The following is a description of a gene set: Mouse Gene Set: GOBP_NEGATIVE_REGULATION_OF_HEMOPOIESIS studied in species Mus musculus Any process that stops, prevents or reduces the frequency, rate or extent of hemopoiesis., and this is the list of marker genes: Inpp4b, Cartpt, Il17d, Hmgb3, Bcl6, Pilrb1, Id2, Clec2d, Nf1, Cul4a, Gpr55, Cdk6, Nme1, Hoxa7, Shh, Ihh, Pias3, Tjp2, Tcta, Irgm1, Pglyrp3, Dtx1 (NCBI Gene Id 14357), Zbtb46, Lgals1, Nfkbid, Prdx2, Flt3, Lyn, Clec4g, Nme2, Hmgb1, Tmem178, Inpp5d, Cd44, Zc3h12a, Foxj1, Loxl3, Cd69, Socs1, Clec2i, Trib1, Zfp608, Cd74, Smad7, Mafb, Gata2, Jak3, Ctla4, Pglyrp2, Pf4, Runx1, Pira12, Slc4a2, Hspa9, Zfpm1, Nrarp, Rag2, Rara, Ccl3, C1qc, Tob2, Snai2, Clec12a, Pglyrp4, Anxa1, Myc, Zc3h8, Tbx21, Rc3h2, Foxp3, Cdkn2a, Tsc22d1, Adipoq, Tnfaip6, Erbb2, Bmp4, Cldn18 (NCBI Gene Id 56492), Zfp35, Fbxo7, Lilrb4a, Il4, Apcs, Mdk, Tnfsf18, Ifng (interferon gamma), Prdm16, Irf1, Ifnb1, H2-M3, Ceacam1, Sfrp1, Ltf, Gli3, Lag3, Bmyc, Fbxw7, Hlx, Tnfsf4, Fgl2, Tmem176a, Qki, Tmem176b, Gpr137, Lrrc17, Gpr68, Il4ra, Pglyrp1, Fbn1, Ctnnb1, Ascl2, Iapp, Runx3, Erfe, Clec2g, Cebpa, Socs5, Gpr137b, Rc3h1, Thoc5, Tnfrsf11b, Lilrb4b, Hspb1 (heat shock protein 1), Ptpn2, Zbtb7b, Fstl3, Pira1, Tmem131l, Pik3r1, Cbfb, Ubash3b, Il2